The following is a description of a gene set: Human Gene Set: GOBP_MESENCHYMAL_TO_EPITHELIAL_TRANSITION_INVOLVED_IN_METANEPHROS_MORPHOGENESIS studied in species Homo sapiens A transition where a mesenchymal cell establishes apical/basolateral polarity,forms intercellular adhesive junctions, synthesizes basement membrane components and becomes an epithelial cell that will contribute to the shaping of the metanephros., and this is the list of marker genes: STAT1, GDNF, GREM1, WNT9B, CTNNB1, PAX2, SMO, PAX8, SALL1, LIF, SIX2